Given this list of marker genes SLC45A2, SLC38A8, OCA2, MC1R (melanocortin 1 receptor), TYRP1, here is a description of the gene set: Abnormal decussation of the visual pathways, typically identified using visual evoked potentials (VEP) (asymmetrical distribution of the VEP over the posterior scalp). studied in species Homo sapiens Optic nerve misrouting Human Gene Set: HP_OPTIC_NERVE_MISROUTING